Given this list of marker genes HTR4, SLC6A4, HTR2B, HTR1B (5-hydroxytryptamine receptor 1B), HTR2C, HTR2A, HTR1A, HTR1E, HTR1F, HTR3A, here is a description of the gene set: Binding to serotonin (5-hydroxytryptamine), a monoamine neurotransmitter occurring in the peripheral and central nervous systems, also having hormonal properties. Human Gene Set: GOMF_SEROTONIN_BINDING studied in species Homo sapiens